The following is a description of a gene set: species: Homo sapiens Any process that activates or increases the frequency, rate or extent of endoplasmic reticulum unfolded protein response. Human Gene Set: GOBP_POSITIVE_REGULATION_OF_ENDOPLASMIC_RETICULUM_UNFOLDED_PROTEIN_RESPONSE, and this is the list of marker genes: AGR2, BOK, DAB2IP, BAX, ATF6, PIK3R1, ERN1, BCL2L11, PTPN2, BBC3, TMEM33, BAK1, PTPN1